Given this list of marker genes PIGS, PIGK, GPAA1, PIGU, PIGT, here is a description of the gene set: species: Homo sapiens An enzyme complex which in humans and yeast consists of at least five proteins; for example, the complex contains GAA1, GPI8, PIG-S, PIG-U, and PIG-T in human, and Gaa1p, Gab1p, Gpi8p, Gpi16p, and Gpi17p in yeast. Catalyzes the posttranslational attachment of the carboxy-terminus of a precursor protein to a GPI-anchor. Human Gene Set: GOCC_GPI_ANCHOR_TRANSAMIDASE_COMPLEX